Given this list of marker genes NFIL3, TRIM13, IPCEF1, NAMPT, ZFX, TRAF3, NFE2L2, FPR1, BCL10, NFE2L1, PMAIP1, NFIC, PPP1R16B (protein phosphatase 1 regulatory subunit 16B), BTG2, LITAF, here is a description of the gene set: studied in species Homo sapiens from publication Zhang JP, Ying K, Xiao ZY, Zhou B, Huang QS, Wu HM, Yin M, Xie Y, Mao YM, Rui YC (PMID 14639605) Genes up-regulated in HL-60 cells (promyeloid leukemia) by cantharidin. Cantharidin is a natural toxin that has antitumor properties and causes leukocytosis as well as increasing sensitivity of tumor cells resistant to other chemotherapeutic agents. There is limited information, however, on the molecular pharmacological mechanisms of cantharidin on human cancer cells. We have used cDNA microarrays to identify gene expression changes in HL-60 promyeloid leukemia cells exposed to cantharidin. Cantharidin-treated cells not only decreased expression of genes coding for proteins involved in DNA replication (e.g., DNA polymerase delta), DNA repair (e.g., FANCG, ERCC), energy metabolism (e.g., isocitrate dehydrogenase alpha, ADP/ATP translocase), but also decreased expression of genes coding for proteins that have oncogenic activity (e.g., c-myc, GTPase) or show tumor-specific expression (e.g., phosphatidylinositol 3-kinase). In contrast, these treated cells overexpressed several genes that encode intracellular and secreted growth-inhibitory proteins (e.g., BTG2, MCP-3) as well as proapoptotic genes (e.g., ATL-derived PMA-responsive peptide). Our findings suggest that alterations in specific genes functionally related to cell proliferation or apoptosis may be responsible for cantharidin-mediated cytotoxicity. We also found that exposure of HL-60 cells to cantharidin resulted in the decreased expression of multidrug resistance-associated protein genes (e.g., ABCA3, MOAT-B), suggesting that cantharidin may be used as an oncotherapy sensitizer, and the increased expression of genes in modulating cytokine production and inflammatory response (e.g., NFIL-3, N-formylpeptide receptor), which may partly explain the stimulating effects on leukocytosis. Our data provide new insight into the molecular mechanisms of cantharidin. Human Gene Set: ZHANG_RESPONSE_TO_CANTHARIDIN_UP